Given this list of marker genes LRP5, IL12B, GATA5, COL1A2, VPS13B, BCAS3, FLNA, SMC3, HRAS, NSD2, GJA8, BRIP1, NOTCH1, BRCA1, NPR3, VPS37D, NKX2-6, COX7B, GTF2IRD1, COL2A1, FANCM, GATA6 (GATA binding protein 6), SKIC2, NFE2L2, NDUFB11, BICC1, ABCC6, PPP2R5D, MAT2A, NEDD4L, PRDM16, FLT4, MMP14, ATP6V1E1, RNF135, DYNC2LI1, PRKACB, GJA5, BAZ1B, MYPN, PRKACA, MLX, PRDM5, DNAJB11 (DnaJ heat shock protein family (Hsp40) member B11), CCDC22 (coiled-coil domain containing 22), MCTP2, KIF3B, FDFT1, EDNRA, ADA2, PRKCZ, IPO8, RIGI, DLL4, TMEM260, ZNF462, EIF4H, IFT140, BRF1, RBPJ, PRKCSH, AGR2, SLC6A6, DOCK6, WAC, FKBP6, KCNE5, ROBO1, EOGT, RASA2, SF3B4, BMP4, NCF1, NF1, SLC29A3, ZNF469, TGFB3, MYOCD, SOS2, BUD23, GABRD, POLR3A, GATA4, TPM3, RAC1, IDS (iduronate 2-sulfatase), SACS, LZTR1, HGD, SPTBN1, HCN4 (NCBI Gene Id 10021), TMTC3, LUZP1, SMAD2, SNX10, PIGG, CLIP2, SH3PXD2B, COMT, FANCL, MYH6, B3GALT6, FANCF, DCHS1, H3-3A, MAP3K7, SEMA3E, TCIRG1, CAPN15, FIBP, ACTB, KMT2D, SOS1, SH2B1 (SH2B adaptor protein 1), MMP23B, TBX1, TMEM270, RIT1, PACS1, KRAS, PLOD1, MYH3, CREBBP (NCBI Gene Id 1387), ARF1, SCAF4, PDPN, PPP1R13L, AEBP1, ZNF699, NADSYN1, ALG5, BRAF, COL1A1, SALL1, OGT, FANCI, TBL2, ALG9, PLD1, CBS, PIK3CA, MYLK, ERCC4, TNXB, MMP2, CHST14 (carbohydrate sulfotransferase 14), FBN1, RYR1, ARHGAP31, CITED2, DAW1, PRKAR1A, GANAB, PKD2, TGFBR1, ROR2, MTX2 (metaxin 2), NKX2-5, MAP1B, MED12, VWF, PPM1D, IDUA, ADAMTS15, FANCB, SNIP1, PUF60, CPLX1 (complexin 1), NONO, PIGL, LRPPRC, SPEN, ARVCF, CTBP1, HSPG2, HLA-B, ARSK (arylsulfatase family member K), SEC63, ATRX, POLR1A, SKIC3, GNB2, CASZ1, DPYSL5, GP1BB, SKI, ADAMTS19, UBE4B, GUSB, RPS6KA3, CHD7, AMMECR1, HCCS, NRAS, RPL26, MYH11, FANCG, GLA, SELENON, TWNK, CHRNG, ADNP, KDM6A, TGFBR2, GLB1, ERMARD, H3-3B, FANCD2, TMEM94 (NCBI Gene Id 9772), WT1, WASHC5, PTPN11, RFWD3, COL5A2, IFT122, GALE, ELN, KCNAB2, CLIC2, KCNJ8, XRCC2, SPEG, RAP1B, THBS2, DNASE1L3, GALNS, BCOR, CLCN7, XYLT1, BRCA2, FBN2, SMAD4, FREM1, SEC24C, EVC2, RERE, MYCN, TBX20, SLX4, SMAD6, SLC34A2 (NCBI Gene Id 153010), KIF7, B3GLCT, TGFB2, UBE2T, DPF2, FOXE3, ZMPSTE24, GLI1, ROBO4, BBS2, DACT1, JMJD1C, RAD51C, DDX3X, SMPD1, B3GAT3, HEXB, GTF2IRD2, RAI1, RFC2, PLCH1, TMEM70, GNPTAB, ZMYM3, HNRNPK, FOXF1, NAA10 (N-alpha-acetyltransferase 10, NatA catalytic subunit), NOTCH3, SGO1, BGN, SPRED2, TAF2, EXTL3, SMAD3, FMR1, RAF1, SRY, TBX5, DOHH, ABCC9, AGO2, PLXND1, NFIX, DZIP1, FMN2, DNAJC30, DSE, GJA1 (gap junction protein alpha 1), EP300, UFD1, ZFX, ZEB2, ANK1, EVC, METTL27, RREB1, LMNA, PALB2, LOX, TAB2, KANSL1, FANCA, YY1 (YY1 transcription factor), LIMK1, HNRNPH2, CBL, POLA1, TLL1, AGGF1, ACTA2, TTN, COL3A1, TRAF7, PKD1, FANCE, DYRK1A, THSD4 (NCBI Gene Id 79875), ACTC1, HEY2, JPH2, ACSL4, MAD2L2, NXN, MYH7, RRAS2 (RAS related 2), MRAS, FGFR1, TNFSF11, MAP2K2, ARFGEF2, PRG4, LTBP3, RAD51, SMARCA4, MAPK1, RPL5, GBA1, NELFA, BIN1, FANCC, SLC25A24, CHST3, PCGF2, GTF2I, IFIH1 (interferon induced with helicase C domain 1), MYRF, POLG, VPS35L, XYLT2, SPRED1, MLXIPL, MFAP5, TPM2, MAP2K1, YY1AP1, PRKG1, HIRA, TPM1, NIPBL, ZIC3, COL5A1, CCNQ, LETM1 (leucine zipper and EF-hand containing transmembrane protein 1), MMP21, KAT5, RRAS, ENPP1, STX1A, here is a description of the gene set: Human Gene Set: HP_ABNORMAL_HEART_VALVE_MORPHOLOGY Abnormal heart valve morphology Any structural abnormality of a cardiac valve. species: Homo sapiens